Given this list of marker genes SETD5, PRDM16, ASH1L, MECOM, SETDB2, SETDB1, here is a description of the gene set: Catalysis of the reaction: L-lysyl9- + S-adenosyl-L-methionine = H+ + N6-methyl-L-lysyl9- + S-adenosyl-L-homocysteine. This reaction is the addition of a methyl group to the unmethylated lysine residue at position 9 of histone H3, producing histone H3K9me. studied in species Homo sapiens Human Gene Set: GOMF_HISTONE_H3K9_MONOMETHYLTRANSFERASE_ACTIVITY